Given this list of marker genes Gnat1, Cngb3, Rd3, Cnga1, Myo5a, Arr3, Col11a1, Cnnm4, Spata7, Slc38a8, Crybb2, Rp1, Nxnl2, Opn5, Crygs, Rp1l1, Lamb2, Cacnb2, Cacna2d4, Opa1, Col2a1, Ppef2, Guca1b, Crygf, Cacna1f, Crygd, Gucy2f, Cabp1, Slc24a1, Gja3, Rpe65, Pax6, Sox14, Elfn1, Crygc, Sema5a, Crybb3, Ndufs4, Abca4, Opa3, Myo7a, Bbs10, Rrh, Pde6h (phosphodiesterase 6H, cGMP-specific, cone, gamma), Cryaa, Bbs1, Cryba4, Gucy2e, Dram2, Pdc, Cngb1, Glra1, Cabp2, Crb1, Rdh10, Slc4a7, Whrn, Dnajc19, Rlbp1, Pde6c, Lrat, Pde6a, Gpr179, Gjc1, Cabp4, Cryba2, Pdcl, Rdh11, Cryba1, Gnat3, Cnga3, Myo3b, Cdh23, Rorb, Grm6, Nyx, Zic2, Sema5b, Unc119, Lctl (NCBI Gene Id 235435), Trpm1, Lypd6, Rdh5, Cln5, Atp8a2, Slitrk6, Dll4, Cryge, Mip, Clrn1, Opn1sw, Impg1, Crybb1, Nob1, Rdh12, Rom1, Lrit1, Gprc5c, Rcvrn, Olfm2, Ush2a, Ppt1, Gabrr2, Dnajc19-ps (DnaJ heat shock protein family (Hsp40) member C19, pseudogene), Adgrv1, Cryga, Cln8, Rpgrip1, Rpgr, Crygb, Impg2, Lrit3, Mfrp, Cplx3, Glrb, Opn4, Crybg3, Rgs9, Best1, Cacnb4, Prph2 (NCBI Gene Id 19133), Pcare, Kcnk9, Rgr (NCBI Gene Id 57811), Opn1mw, Cep250, Pde6b, Gja10, Bbs2, Rdh8 (NCBI Gene Id 235033), Ush1g, Wfs1, Kcnj10, Cfh, Rgs9bp, Clic5, Crx, Guca1a, Ush1c, Gjd2, Irx5, Crygn, Epas1, Lamc3, Rbp4, Chrnb2, Cln6, Cplx4, Bfsp2, Slc45a2, Gnat2, Tulp1, Nr2e1, Th, Slc4a10 (solute carrier family 4, sodium bicarbonate cotransporter-like, member 10), Cldn19, Atf6, Vsx1, Pde6d (phosphodiesterase 6D, cGMP-specific, rod, delta), Pde6g, Reep6, Grk1, Vsx2, Rs1, Col1a1, Ccdc66, Pcdh15, Rho, Myo3a, here is a description of the gene set: The series of events required for an organism to receive a sensory light stimulus, convert it to a molecular signal, and recognize and characterize the signal. This is a neurological process. Mouse Gene Set: GOBP_SENSORY_PERCEPTION_OF_LIGHT_STIMULUS studied in species Mus musculus